Given this list of marker genes ADORA1, NPY, PCSK6, HAP1, FURIN, here is a description of the gene set: Human Gene Set: GOBP_NEUROTROPHIN_PRODUCTION The appearance of a neurotrophin due to biosynthesis or secretion by cells in a neuron's target field, resulting in an increase in its intracellular or extracellular levels. A neurotrophin is any of a family of growth factors that prevent apoptosis in neurons and promote nerve growth. studied in species Homo sapiens